Given this list of marker genes MFAP5, ITGB3, BMP4, FURIN, TGFB3, FBLN1, LOX, ITGB8, ITGAV, MFAP3, ITGA5, LTBP4 (NCBI Gene Id 8425), EMILIN3, EMILIN1, MFAP4, FBLN2, ELN, EMILIN2, BMP10, FN1, BMP7, ITGB5, ITGB1, BMP2, LOXL3, FBN2, LTBP3, GDF5, TGFB2, LOXL4, TGFB1, VTN, FBLN5, EFEMP2, LTBP2, ITGB6, LOXL2, LOXL1, MFAP2, LTBP1, FBN3, ITGA8, EFEMP1, FBN1, here is a description of the gene set: Human Gene Set: REACTOME_ELASTIC_FIBRE_FORMATION Elastic fibre formation studied in species Homo sapiens